The following is a description of a gene set: The process in which the anatomical structures of the viscerocranium are generated and organized during the embryonic phase. The viscerocranium is the part of the skull comprising the facial bones. Mouse Gene Set: GOBP_EMBRYONIC_VISCEROCRANIUM_MORPHOGENESIS studied in species Mus musculus, and this is the list of marker genes: Lhx1, Tbx1, Ndst1, Nipbl, Mthfd1l, Hoxa2, Rdh10, Chst11, Foxc2, Mef2c